The following is a description of a gene set: species: Mus musculus Mouse Gene Set: GOBP_ISOPENTENYL_DIPHOSPHATE_BIOSYNTHETIC_PROCESS The chemical reactions and pathways resulting in the formation of isopentenyl diphosphate, an isomer of dimethylallyl diphosphate and the key precursor of all isoprenoids., and this is the list of marker genes: Idi2, Mvk (mevalonate kinase), Idi1, Mvd, Pmvk